Given this list of marker genes GNG4, ACVR1, LARP7, VXN, EIF3M, TECRL, PPP1R2, USP9Y, ERO1B, DMXL1, TAPT1, TCF7L1, POU2F2, DYNC2H1, SSR1, MYBL1, APBB2, CDH7, LRP2BP, NAMPT (nicotinamide phosphoribosyltransferase), ARHGAP6, DMTF1, ZBTB20, SESN3, RMDN1, ZXDB, SPRY1, FYTTD1, CSRNP3, DNHD1, VKORC1L1, XRCC2, TDRP, SHMT1, MFHAS1, UBN2, KLF7, HMGA1, SORBS2, MAK16, KCTD16, PLCL1, ZEB2, SCN7A, IRS2, EIF4G2, FOXN2, CHIC1, FN3KRP, IDH2, RBL2, CREBZF, DGKH, CD99, SEMA3C, RER1, GABRB2, ANKRD11, PPAT, FMO1, EPHA6, TSHR, JMY, ARID1B, GNG10, CDH10 (cadherin 10), MAGI1, RAB3B (RAB3B, member RAS oncogene family), SNX1, ENPP6, REPS1, DZIP1L, ECM2, GABBR2, ARHGEF11 (NCBI Gene Id 9826), POLA1, ARL4C (NCBI Gene Id 10123), SLC17A6, FAT3, RAI2, GABBR1 (gamma-aminobutyric acid type B receptor subunit 1), EPM2A, CNTLN, ATG5, ZNF330, E2F5, UBE4A, PHACTR2, CD1E, GTF2I, FGD1 (FYVE, RhoGEF and PH domain containing 1), SLC6A14, SP1, BDH1, SLC35E4, SCN2A, NCOA2, ALDH1L2, POLR3F, LANCL2, ARG2, IL23R, KCNQ3, ECHDC2, USF3, CDH13, DGKE, ATRX, KRTAP9-9 (NCBI Gene Id 85279), HSPA12A, SYNJ1, FGF14, EFR3A, ASB14, PPEF2, PUM2, DNAJC25-GNG10, DUSP1, PPP1R8, MAP3K1, MIXL1, MAPK1, NR1D2, AMER2, BBS7, KHSRP, PAPOLA, PLP1, UST (uronyl 2-sulfotransferase), UBXN2B, RAB6A, HNRNPU, DCLK1, MBNL1 (NCBI Gene Id 9850), BACH2, KAT6A, RBM41, SRD5A3, WNK2, LNPK, RNF6, GALNT13, CCDC115, MPZL2, RPL15, DPP4, TLK2, ANK2, ZSCAN20, TBC1D12, HNRNPA3, WIPF2, here is a description of the gene set: Genes predicted to be targets of miRBase v22 microRNA hsa-miR-3611 in miRDB v6.0 with MirTarget v4 prediction scores > 80 (high confidence targets). Human Gene Set: MIR3611 studied in species Homo sapiens from publication Chen Y, Wang X (PMID 31504780)